Given this list of marker genes ELN, PRR29, IL32, MALSU1, MGP, SLC6A8, TNFSF10, PNP, MMP10, IFI27, BCKDHA, ADGRE1, KRT7, HEXA, AQP7, GGH, PIM1, LMO2, TIE1, MRPL19, SHC3, ANGPT2, SAT1, PDE4B, MMP1, BGN, PIR, NNMT, GSTT1, ESR1, BMP4, GCHFR, MPHOSPH10, CCL2, RANGAP1, RALA, PRKCI, RBX1, CXCL1 (C-X-C motif chemokine ligand 1), CEACAM1, ADD2, SULT1E1, DYNLL1, GJA4, UNG, ISL1, KDR, ANKRD1, PGF, DLEU2, HSD11B2, HEMGN, SP3, CD34, NDUFA1, CD9, BMP6, EFEMP1, GALNT1, TFPI2, HCLS1, NR4A1, FOXO1, FGFBP1, VWF, TRIM23, here is a description of the gene set: studied in species Homo sapiens from publication Weston GC, Haviv I, Rogers PA (PMID 12200464) There is evidence that the vasculature of different organs display different functional characteristics in response to cytokines and growth factors. The aim of this study was to use cDNA gene expression microarray to analyse changes in gene expression following stimulation of myometrial microvascular endothelial cells (MMECs) with vascular endothelial growth factor (VEGF). Primary isolates of MMECs were obtained from fresh hysterectomy specimens and purified with magnetic beads. Cells were stimulated with 15 ng/ml VEGF for 3, 6 and 12 h, and two unstimulated experiments served as controls. A total of six arrays was performed over these time-points. A total of genes were identified as up-regulated by VEGF, 19% of which (genes) have previously been reported as up-regulated by VEGF or by angiogenesis. Among the novel genes to be up-regulated by VEGF were brain-derived growth factor, oxytocin receptor and estrogen sulphotransferase. The significance of the genes identified in the physiological and pathological functioning of the myometrial vasculature is discussed. Genes up-regulated in MMEC cells (myometrial endothelium) at 3 h after VEGFA stimulation. Human Gene Set: WESTON_VEGFA_TARGETS_3HR